The following is a description of a gene set: Human Gene Set: GOBP_GLYCINE_TRANSPORT The directed movement of glycine, aminoethanoic acid, into, out of or within a cell, or between cells, by means of some agent such as a transporter or pore. species: Homo sapiens, and this is the list of marker genes: SLC38A1, SLC32A1, SLC6A9, SLC6A7, SLC6A5 (solute carrier family 6 member 5), SLC6A20, SLC7A8, RGS4, SLC7A10, SLC38A5, SLC36A1, SLC6A17, RGS2, SLC36A3, SLC25A38, SLC6A14, SLC36A2